Given this list of marker genes HMOX1, ABCB6, STEAP2, TTC7A, FBXL5, NCOA4, FTMT, SOD1, MIR210, BOLA2, CP, CYBRD1, TFR2, SMAD9, MECR, ATP13A2, FLVCR1, SMAD4, BMP6, IREB2, TMPRSS6, LCN2, ATP6V0D1, SMAD5, SMAD1, HAMP, SLC40A1, ATP6V1G1, GLRX5, FRRS1, FTL, FTH1P19, SLC46A1, SLC11A2, NUBP1, SLC11A1, TFRC, HFE, ATP6AP1, ACO1, EGLN1, BOLA1, HJV, TMEM199, GLRX3, ATP6V1A, B2M (beta-2-microglobulin), ISCU, SLC39A14, CYB561, STEAP4, IFNG, BOLA3, CYB561A3, HEPHL1, ACVR2B, FTHL17, TF, PICALM, NEO1, ATP6V0A2, CCDC115, HIF1A, SLC22A17, NDFIP1, ERFE, FTH1, MYC, BOLA2B, SCARA5, ABCB7, HPX (NCBI Gene Id 3263), CISD1, ALAS2 (5'-aminolevulinate synthase 2), FXN, SLC39A8, GDF2, here is a description of the gene set: Human Gene Set: GOBP_INTRACELLULAR_IRON_ION_HOMEOSTASIS A homeostatic process involved in the maintenance of a steady state level of iron ions within a cell. studied in species Homo sapiens